The following is a description of a gene set: studied in species Homo sapiens The presence of a neoplasm of the urinary system. Human Gene Set: HP_URINARY_TRACT_NEOPLASM Urinary tract neoplasm, and this is the list of marker genes: NRAS, CTNNB1, ATP7A, HRAS (NCBI Gene Id 338029), MVK, RNF43, REST, PIK3CA, CDC73, SEC23B, POU6F2, PTCH1, SDHD, DICER1, MUTYH, ASXL1, CDKN1C, SOX9, DLC1, HNF1A, ZFPM2, ATM, NR5A1, FGFR3, CDKN2A, WT1 (NCBI Gene Id 7490), VAMP7, FOXE1, FIBP, AXIN2, NOD2, PMS2, GNAS, NTHL1, KCNQ1OT1 (NCBI Gene Id 11111), POLE, POLD1, COL14A1, BMPER, PAX6, KDM1A, PMS1, BAX, MAX, PALB2, C1S, DLST, MSH6, MET, KLLN, KCNQ1, FLCN, AAGAB, PTPRJ, BMPR1A, EXT2, NR0B1, TRIM28, EPCAM, CDKN1B, TGFBR2, MAP3K1, SEMA4A, SDHAF2, RPS20, RET, MCC, TSC2, APC, PTEN, RAD54B, HABP2, GPC4, DCC, ALX4, H19, CCND1, CEP57, NF1 (NCBI Gene Id 646021), GATA4, MLH3 (mutL homolog 3), EP300, PTPN12, TSC1, BUB1, TMEM127, PBRM1, BUB1B (BUB1 mitotic checkpoint serine/threonine kinase B), SLC25A11, WWOX, SDHB, USF3, HDAC4, SRC, DHX37, MDH2, GPC3, TP53 (tumor protein p53), IFNG, B3GALT6, AURKA, SPRED1, MINPP1, FH, KEAP1, IGF2, MSH2, ARMC5, MDM2, BAP1, LMNA, SDHA, BUB3 (NCBI Gene Id 9184, BUB3 mitotic checkpoint protein), DIS3L2, RNF139, PDGFRL, SMARCA4, BRCA2, PLA2G2A, CHEK2, FERMT1, SETBP1, SDHC, HNF1B, AKT1, MLH1, KRAS, TLR2 (toll like receptor 2), TRIP13, OGG1, SRY, KIF1B, TRIM37, PRDM10, TFE3, VHL, BLM, PHF21A, WRN, RB1, BRAF, STK11, PRCC